The following is a description of a gene set: from publication Chen Y, Wang X (PMID 31504780) species: Mus musculus Mouse Gene Set: MIR_449A_5P Genes predicted to be targets of miRBase v22 microRNA mmu_miR_449a_5p in miRDB v6.0 with MirTarget v4 prediction scores > 80 (high confidence targets)., and this is the list of marker genes: Gpr22, Mmp25, Fut9, Arid4b, Kcna6, Ppargc1b, Tbl1xr1, Akap6, Ago4, Chd1, Tppp, Rtl4, Mgat4a, Slc4a8, Dpp8, Ei24, Gmfb, Mycn, Snx12, Klf4, Celf3, Cntn2 (contactin 2), Synj1, Ppp1r11 (NCBI Gene Id 76497), Mta2, Dcx, Thtpa, Slc4a7, Rras, Tbc1d2b, Slc25a27, Golph3l (NCBI Gene Id 99919), Arap1, Zmym4, Sema4c, Calcb, Metap1, Tmem45a2, Fut8, Htr2c, Bnc2, Unc13c, Pip5k1a, Ppm1b, Lef1, Gm14326, Pitpnc1, Shkbp1, Mdm4, Lman2l, Csf1r, Vwa5b2, Speer4a1, Etl4, Numbl, Dcaf7, Casp2, Camta1, Dixdc1, Arhgap1, Notch2, Arhgap26, Itch, Tmed8, Ccne2, Syt1, Rfx3, E2f3, Ttc19, Pea15a, Cacna2d2, Tent5a, Abtb3, Ubl4a, Hexa, Tmem164, Calcr, Snai1, Add2, Bcl6, Usf1, Cuedc1, Satb2, Ahcyl2, Frk, Coro1c, Mpp2, Snx15, Ptms, Ltbp2 (NCBI Gene Id 16997), Gsto1, Met, Map2k1, Srpra, Brinp1, Fam76a, Ddx17, Dgkb, Chmp7, Gm14391, Kcng2, Nav3, Wscd2, Rtn4rl1, Kti12, Rmnd5a, Serpinf2, Tpd52, Azin2, Zdhhc16, Creb3l2, Kitl, Nrip3, Atg4b, Usp31, Brpf3, Osgin2, Jade2, Rhbdl3, Pogz, Ldha, Mllt3, Eml5, Ankrd52, Nectin1, Galnt7, E2f5, Scamp4, Tmem79, Fam107a, Btn1a1, Notch1, Mgat5b, Tom1, Fam83h, Nav1, Stag3, Zfp282, Hspb6, Erc1 (NCBI Gene Id 78063), 9930012K11Rik, Trank1, Vamp2, Asic2, Vat1, Abr, Lgr4, Plcb1, Rab21, Cdc25a, Hcn3, Rhoh, Erp44, Abcd1, Pacs1, Rhoj, Thumpd1, Lman1, Pdgfra, Smim15 (small integral membrane protein 15), Sgta, Zkscan16, Rab43, Zfp281, Car10, Rps6ka4, Rragc, Daam1, Foxn2, 4930544G11Rik, Clcn3, Tmem255a, Asb1, Ubp1, Ldb3, Foxj2, Ing5, Tnrc6b, Taf5, Acsl1, Ucn2, Fbxo30, Slc25a53, Vcl, Zfp644, Zfp120, Slc6a1, Mtcl2, Pxdc1, Aff4, Mmab, Krtap16-1, Gabra3, Sidt2, Atp2b4, Dgkz, Sirt1, Pacc1, Lyplal1, Dpysl4, Car7, Slc44a2, Tanc2 (tetratricopeptide repeat, ankyrin repeat and coiled-coil containing 2), Pkp4, Polq, Gpr158, Gpr165, Strn3, Svop, Lhx2, Gdf2, Mex3c, Gmnc (NCBI Gene Id 385639), Il6ra, Tgif2, Ppp2r5a, Scn2b, Ergic1 (NCBI Gene Id 67458), Scml2, Nat8l (NCBI Gene Id 68762), Patz1, Ccdc85a, Cbfa2t3, Rimoc1, Ppp2r3a, Pnoc, Slc35g2, Acsl4, Ppfia1, Vdr, Isg20, Cplx2, Lzts3, Zfp512